Given this list of marker genes TMEM170A, BTBD10, MTFR1, MOSPD1, TTI2, AP5M1, TOR1AIP1, THAP9, LITAF (lipopolysaccharide induced TNF factor), MRPL50, EEF1E1, GOSR2, TLR1, FCF1, DLAT, SLC17A5, CFL2, BMP2K, PPP2CA (NCBI Gene Id 5515), HARS2, EFR3A, RFC5, CCDC71L, ZCCHC10, CRKL, FAM217B, RP2, RMC1, C5orf22, SLC30A5, RNF168, TMEM185B, YIPF5, C11orf54, KIFBP, ACVR1B, UNC50, ZNF230, IMPA1, RFLNB, C15orf40, MTMR10, CLNS1A, RBSN, SLC25A44, ERLEC1, KLHL12, SMNDC1, DCUN1D5, MAP2K4, SEC23A, LYSMD2, SPAG1, PRMT6, RBM15, PHF3, DERL2, SMIM15, LRRC57, KPNA1, RAB22A, MRPL13, HSDL2, HAT1, ZFR, RUNDC1, RFFL, RTF1, MFAP1, GMEB1, OR2L13, ABHD2, C1orf43, MTMR9, WASL (NCBI Gene Id 8976), ZBTB26, MINPP1, ZNF684, ZCCHC9, SLC9A6, FAM120AOS, TIMP1, DHTKD1, TP53RK, SPRTN, DCAF10, MRPS16, CSE1L, FEN1, SERINC1, LYSMD3, ZNF410, DESI2, SENP2, RNF114, MFAP3, ARF4, PAPOLG, COX5A, CCNE2, DEGS1, TOX4, CCDC90B, ZNF764, LINC00324, ZNF644, CCDC28A, WIPF2, LPAR2, GTPBP1, ARCN1, SLC25A12, MED23, RRAGA, DBR1 (debranching RNA lariats 1), TNFSF14, APPBP2, TMEM33, BAG4, ACYP2, EGR2, DUSP11, EGR3, PCTP (phosphatidylcholine transfer protein), PHF20L1, ALG2, NAA30, NR3C1, ODR4 (NCBI Gene Id 54953), DCUN1D1, ATP5MC3, CPQ (carboxypeptidase Q), ATP6V1H, MGAT2, NUDT19, KNL1, TTC33, TSN, MRPS18A, CCNYL1, COPS5 (COP9 signalosome subunit 5), METTL21A, SLC66A2, NUP35, RBBP5, PTPMT1, EMC7, TMEM50B, THAP1, ZNF620, SEPHS2, RAB21, ZNF708, ZWILCH, TM9SF2, KBTBD7, PRPF4, VPS33B, ZNF10, PPP2R3C, CCDC137, TBC1D23, FEM1C, USP3-AS1, ZUP1, SLC25A32, SPIDR, UFD1, E2F5, FBXO5, ZSCAN16, IKBIP, C8orf76, SETMAR, STAU1 (staufen double-stranded RNA binding protein 1), FAM98A, SGPL1, LAMTOR3, ZNF200, RCOR1, SELENOT, PARPBP, SGO2, CPD, CPT2, FANCM, KIN, AURKA, ASCC3, GRSF1, CCNDBP1, DIMT1, TEX30, MRGBP, ZNF227, CEP57L1, here is a description of the gene set: from publication Querec TD, Akondy RS, Lee EK, Cao W, Nakaya HI, Teuwen D, Pirani A, Gernert K, Deng J, Marzolf B, Kennedy K, Wu H, Bennouna S, Oluoch H, Miller J, Vencio RZ, Mulligan M, Aderem A, Ahmed R, Pulendran B (PMID 19029902) Genes up-regulated in comparison of unstimulated peripheral blood mononuclear cells (PBMC) versus PBMC 1 day after stimulation with YF17D vaccine. The immune responses generated by YF-17D by profiling genes in 25 vaccine recipients were accessed at days 1, 3, 7, and 21 post-vaccination compared to pre-vaccination in PBMCs. The immune responses generated by YF-17D by profiling genes in 25 vaccine recipients were accessed at days 1, 3, 7, and 21 post-vaccination compared to pre-vaccination in PBMCs. Human Gene Set: GSE13485_CTRL_VS_DAY1_YF17D_VACCINE_PBMC_UP species: Homo sapiens